The following is a description of a gene set: Human Gene Set: HP_CHRONIC_CSF_LYMPHOCYTOSIS Chronic cerebrospinal fluid (CSF) lymphocytosis is defined as the finding, in at least two serial CSF examinations, of more than 5 cells per cubic millimeter. studied in species Homo sapiens Chronic CSF lymphocytosis, and this is the list of marker genes: TREX1, RNASEH2A, RNASEH2B, SAMHD1, ADAR, IFIH1, RNASEH2C, LSM11, RNU7-1